The following is a description of a gene set: studied in species Mus musculus A multisubunit chaperone that is capable of delivering unfolded proteins to cytosolic chaperonin, which it acts as a cofactor for. In humans, the complex is a heterohexamer of two PFD-alpha and four PFD-beta type subunits. In Saccharomyces cerevisiae, it also acts in the nucleus to regulate the rate of elongation by RNA polymerase II via a direct effect on histone dynamics. Mouse Gene Set: GOCC_PREFOLDIN_COMPLEX, and this is the list of marker genes: Pfdn2, Pfdn6, Pfdn4, Pfdn1 (prefoldin 1), Pdrg1, Vbp1, Pfdn5